The following is a description of a gene set: Mouse Gene Set: GOMF_INOSITOL_TETRAKISPHOSPHATE_PHOSPHATASE_ACTIVITY studied in species Mus musculus Catalysis of the reaction: myo-inositol tetrakisphosphate + H2O = myo-inositol trisphosphate + phosphate., and this is the list of marker genes: Synj2, Ocrl, Pten, Minpp1, Inpp5j, Inpp5d, Inpp5k